Given this list of marker genes PWWP2B, INSC, UBQLN3, VGLL4, ACOT1, OMP, HS3ST3B1 (NCBI Gene Id 9953), SMIM6, LRRC36, GNPDA2, RHBDL2, EGFL8, AZIN2, ST8SIA3, LRRC56, GARIN5A, TRPM4, KCNJ8, TBC1D10A, FURIN, STXBP5L, BST2, MYL1, CD93, DGKH, NSUN3, CADM2, MAX, DMD, SLC45A3, UNC119, LDB2, IRX3, IL4R, GNG7, MAGIX, HOXC6, UBTD1, RHOBTB3, CCNL1, NEUROD1, ASB16, DSC3, POU2F3, CASR, NEK4, PEMT, PCK1, MAP1LC3B, VCAN, FRMD4B, NAALADL2, C14orf119, DKK4, RBMXL2, CTNNA3, RARB, SHISA2, LYZL6 (lysozyme like 6), PRKD3, GPR35, PPM1J, SMPX, CLRN1, NPY2R, MROH9, SERPINA3, GLIPR2, CHRD, NYNRIN, CACNA1B, B3GALT2, NME3, TP53I13, CLDN15, DDIT3, GDF3, CRY1, GPATCH2, EPHA8, NFIL3, CCDC33, CCDC102A, CYSRT1, KHDC1L, UBTFL1, CERS4, NFE2L2, NGF, MAP3K8, SLC37A2, AAR2, PTPN5, GLIS3, DEGS1, ACADL, ATP6V0E1, DUSP22, TPRN, DDA1, HNF4A (NCBI Gene Id 4339, hepatocyte nuclear factor 4 alpha), UBE2QL1, BRD2, SLC25A44, NPR3, KIAA1614, HAPLN2, ARID3A, HS2ST1, CASP6, PNLIPRP2, CDC73, C12orf56, NEFM, LHX8, ERMN, PRODH2 (NCBI Gene Id 58510), LRRC8C, APRT, GAPDHS, DNAJC3 (DnaJ heat shock protein family (Hsp40) member C3), DNAJC22 (DnaJ heat shock protein family (Hsp40) member C22), NMT2, ITGA10, DMRTA1, HMOX2, TMEM130, AJUBA, LPP, PDPN, KATNBL1, TMEM102, RAB3A, NTN4, TSHB, GAS1, SLC17A9, CHRNA3, STMN4, TGIF2LX, USP43, RAB35, FBXO3, LAPTM4A, PDZD4, IL33, STK40 (NCBI Gene Id 83931), GDNF, SPIC, IQSEC2, ST7L, DPYSL4, TOR2A, RAB19, TLR8, NOL3, IFT43, CGN, NKX3-2, CA13, MDGA2, CLDN8, ZNF469, ST6GALNAC3, ZNF217, ABCC9, S100G, SLC46A2, MYCBPAP, EXPH5, KRT36, CAV3, LEPROTL1, RSPH1, ATG4A (NCBI Gene Id 115201), RIT1, SNHG8, TBC1D9, HCN3, TCF15, METTL4, ADIPOQ, HECW2, NRTN, NCDN, CXCR3, HEXIM2, NCAN, RAC3, DDRGK1, GPR75, MIF4GD, PLEKHF2, CHRNB3, NCOA1 (NCBI Gene Id 8648), EGFL7, SRGN, JSRP1, PCBP1, RPH3AL, here is a description of the gene set: from publication Yang HT, Wang Y, Zhao X, Demissie E, Papoutsopoulou S, Mambole A, O'Garra A, Tomczak MF, Erdman SE, Fox JG, Ley SC, Horwitz BH (PMID 21217011) species: Homo sapiens Genes up-regulated in unstimulated macrophages: IL10 knockout versus NFKB1 knockout. Bone marrow-derived macrophages were produced from mice lacking IL-10 alone (IL10-def) or mice lacking both IL-10 and the p50/p105 subunit of NF-kB (p50/IL10), and left unstimulated, stimulated with LPS (1 ng/ml) or stimulated with LPS and IL-10 (0.3 ng/ml). Human Gene Set: GSE19941_IL10_KO_VS_IL10_KO_AND_NFKBP50_KO_UNSTIM_MACROPHAGE_UP